The following is a description of a gene set: Human Gene Set: GOMF_C_X_C_CHEMOKINE_BINDING studied in species Homo sapiens Binding to a C-X-C chemokine; C-X-C chemokines have a single amino acid between the first two cysteines of the characteristic four cysteine motif., and this is the list of marker genes: ACKR3, CXCR3, CXCR2, CXCR1, HMGB1, A2M